The following is a description of a gene set: from publication Chen Y, Wang X (PMID 31504780) Mouse Gene Set: MIR_7215_3P species: Mus musculus Genes predicted to be targets of miRBase v22 microRNA mmu_miR_7215_3p in miRDB v6.0 with MirTarget v4 prediction scores > 80 (high confidence targets)., and this is the list of marker genes: Rab30, Rptor (NCBI Gene Id 74370), Xpo7 (exportin 7), Tiprl, Mcat, Mapk1 (NCBI Gene Id 98012), Hal, Zfp592 (NCBI Gene Id 330576), Cacul1, Bpi, Stx11, Kpna6, Tfap2a, Snph, Dst, Kcna6, Mapk4, Csrnp3, Ambn, Pank2, H2bw2, Pals1, Crebrf, B4galt1, Otx2, Sgsm1, Ubash3b, Gad2, Stradb, Cmtm4, M1ap, Fbxw7, Ceacam2, Ctps2, Rps6ka5, Kptn, Foxo3, Ddi2, Or8g20 (olfactory receptor family 8 subfamily G member 20), Gprc5b, Wdr91, Tmcc3, Smad2, Neurl4, Pam, Rbm18, Acer3 (alkaline ceramidase 3), Tpd52, Zc3h7a, Gcc1, Tcf12, Rbpms, Lypd6b, Tmt1a2, Cacnb3, Snupn, Mprip, Epha7, Olig2, Fgf6 (fibroblast growth factor 6), Ythdf2 (YTH N6-methyladenosine RNA binding protein 2), Cyp7a1, Zmat2, Poc5, Adarb1, Rufy2, Ptbp3, Sh2d3c, Riox1, Nfat5, Ifit1, Mapre1, Tmem41b (NCBI Gene Id 76341), Tusc2, Ptprr, Tmt1a, Gm11780, Grtp1, Map7, Ceacam1, Lrrc7, Cbl, Mbd6, Ppp2r5a, Lamp2, Kcnj6, Slc25a47, Tmt1a3, Oog2, Kpna1, Clspn, Hnrnpa0, Klhdc8a, Gng2, Kcnk10, Capn7, Plekhg4, Sugt1 (NCBI Gene Id 67955), Chst2, Sarm1, Mical3, Cul3, Crmp1, Zfp442, Tmem222, Asxl3 (ASXL transcriptional regulator 3), Ccsap, Hnrnpk, Ctsc, Mtcp1, Vapb, Itk, Pnrc2, Cdk6, Adra2a, Lhx9, Gigyf2, Abca8b, Hsd3b6, Ltbr, Synpo, Agbl5, Polr2m, Zmat4, Sec14l1, Ankfy1, Batf2, Ncoa7, Efcab2, Hhex, Lrrc58, Ppara, Fryl